Given this list of marker genes LILRA2 (leukocyte immunoglobulin like receptor A2), HAVCR2, CD34, TSLP, ISL1, here is a description of the gene set: species: Homo sapiens The appearance of granulocyte colony-stimulating factor due to biosynthesis or secretion following a cellular stimulus, resulting in an increase in its intracellular or extracellular levels. Human Gene Set: GOBP_GRANULOCYTE_COLONY_STIMULATING_FACTOR_PRODUCTION